Given this list of marker genes Itpkb, Nrg1, Stk19, Shoc2, Hras, Ntrk1, Ephb2 (NCBI Gene Id 13844), Rasgrp1, Dab2ip, Rasgrf1, Src, Mapkap1, Icmt (isoprenylcysteine carboxyl methyltransferase), Rapgef1 (Rap guanine nucleotide exchange factor (GEF) 1), Rasgef1a, Syde1, Ngf, Rasal1, Sh2b2, Tgfb2, Map2k1, Fbp1, Ppp2cb, Kitl, Mfn2, Foxm1, Rabl3, Notch2, Rasa4, Tnk1 (tyrosine kinase, non-receptor, 1), Notch1, Rasal3 (RAS protein activator like 3), Stambp, Timp2, Syde2 (NCBI Gene Id 214806), Lztr1, Nup62, Spry4, Spry2, Mmd2, Erbb2, Spry1, Epo, Csf1, Trim67, Picalm, Sos1, Rabgef1, Fgf10, Igf1, Syngap1, Nf1, Dgki, Rasa3, Flcn, Rasa2, Dgkz, here is a description of the gene set: Mouse Gene Set: GOBP_REGULATION_OF_RAS_PROTEIN_SIGNAL_TRANSDUCTION studied in species Mus musculus Any process that modulates the frequency, rate or extent of Ras protein signal transduction.